The following is a description of a gene set: Human Gene Set: GOMF_SUMO_LIGASE_ACTIVITY studied in species Homo sapiens Catalysis of the transfer of SUMO to a substrate protein via the reaction X-SUMO + S = X + S-SUMO, where X is either an E2 or E3 enzyme, the X-SUMO linkage is a thioester bond, and the S-SUMO linkage is an isopeptide bond between the C-terminal amino acid of SUMO and the epsilon-amino group of lysine residues in the substrate., and this is the list of marker genes: PIAS4, NSMCE2, ZBED1, RANBP2, ZMIZ1, PIAS3, PIAS2, CBX4, ZNF451, PIAS1, ZMIZ2, TRIM60, EGR2, KIAA1586 (KIAA1586)